Given this list of marker genes FMO1, STAT5A, BAAT, GHR, PTER, STAT5B, CSAD, PHGDH, FMO3, CDO1, here is a description of the gene set: studied in species Homo sapiens The chemical reactions and pathways involving alkanesulfonates, the anion of alkanesulfonic acids, sulfonic acid derivatives containing an aliphatic hydrocarbon group. Human Gene Set: GOBP_ALKANESULFONATE_METABOLIC_PROCESS